The following is a description of a gene set: species: Homo sapiens from publication Chen Y, Wang X (PMID 31504780) Human Gene Set: MIR3654 Genes predicted to be targets of miRBase v22 microRNA hsa-miR-3654 in miRDB v6.0 with MirTarget v4 prediction scores > 80 (high confidence targets)., and this is the list of marker genes: FBXW11, ZNF776, ABHD2, GATA2, TMEM68, SECISBP2L, ADAT2, PIM2, AP2M1, DHX36, ZNF638, MED26 (NCBI Gene Id 9441), IQSEC1, SGIP1, HLA-DQA1, MSL2, TBL1XR1, MFSD14A, GSAP, SMIM5, ATG12, CDK8, GSTA4, D2HGDH, CALCB, ZNF134, CAB39L, RPP30, FRS2, TMCO6, KRBOX4, ZNF554, CRNN, CPEB3, PI4K2A, SMURF1, TNFAIP8, FCAR (Fc alpha receptor), TCHP, ACBD5, RAP1B, VANGL1, JAG1 (NCBI Gene Id 3715), PSMA5, ACTBL2, UHRF1